The following is a description of a gene set: species: Homo sapiens Any process that modulates the frequency, rate or extent of addition of phosphate groups into a molecule. Human Gene Set: GOBP_REGULATION_OF_PHOSPHORYLATION, and this is the list of marker genes: FBLN1, CCNG1, RACK1, CARD10, SRPX2, PPIA, EGF, LATS1, C3, TRAF3IP1, BMP2, MAP4K2, CLIP3, TRAF6, KCTD20, PRKN, MAP2K1, TRAF4, DSTYK, SOCS5, SMG8, HDAC3, RBL1, DIRAS2, ROPN1, SIRT1, KLHL31, RALBP1, APOE, IL18, CDK12, AGT, TARBP2, WNT5A, CDK5RAP1, DNAJA1, CDC6, LYN, SEMA4D (semaphorin 4D), EMP2, CASS4, DOK7 (NCBI Gene Id 619409), NOP53, GPRC5A, SMO, GTF2H1, NPPA, HERC5, ADAR, HLA-DRB1, WEE2, TCIM, CDKN2A, CDK2AP1, MACROH2A1, DDRGK1, PDCD4, DIRAS3, DEFB114, CNOT9, STK4, MMP9, MAD2L2, INCA1, ZC3H12A, TRIM27, IFNG, KIT, PTEN, IGF1, CDC25C, STRADB, LIMCH1, TNK2, PAK2, MST1, CACTIN, DIPK2A, CHP1, DRD4, AGAP2, PIH1D1, CD4, GPRC5B, PTPN13, HIPK3, ENG, TPD52L1, UNC119 (NCBI Gene Id 9094), FGF1, EEF1A2, LDB2, PTK2, CLSPN, RAP1A, FLT4, ALS2, ARRB1, XRCC6, ITGB2, ARL2BP, TIGAR, KDR, ZNF622, CDK5R2, NT5DC2 (5'-nucleotidase domain containing 2), PTK2B, ZBED3, PTPRC, MEN1 (menin 1), MOB1B, KSR1, PSMD10, ENPP2, PRR5L, THBS1 (thrombospondin 1), PFN2, NDUFS4, FZD7, GPER1, FGF19, RAP2C (RAP2C, member of RAS oncogene family), FGF16, CDKN1B, RAF1, PDCD10 (NCBI Gene Id 9226), ATG14, VPS25, IL34, TLR6, BCCIP, EZH2, TNFSF15, ARHGEF5, MAP3K10, MAP3K4, ETAA1, DYNAP, WNK3, DIRAS1, VEGFA (NCBI Gene Id 7422), IL21, TBX1, EPHA7, BRAT1, MAP2K2, INHBA, FLOT1, CDK5RAP3, RAP2B, OSM, FAXDC2, GCKR, DSCAM, ADARB1 (NCBI Gene Id 104), ROPN1L, ZGPAT, ITGB1BP1, FGFR3, PKIA, PIK3R5, TAOK3, RARRES2, CD74, FIRRM, NPRL2, TSG101, JTB, THBS4, ANG, ERRFI1, SPHK1, CREBL2, TENM1, ADAM17, TOM1L1, PRKCH, SERTAD1, DNAJC3, SYNPO2, CIB1, IFNL1, SRC, CNKSR3, PHIP, NEK10, YWHAG, ABL1, CIMAP3, RAPGEF2, CADM4, RGS14, HES1, TNFRSF10B, CDC37, TNFSF18, CDC25A, FGF2, CEP85, FGFR1, BRAF, ERN1, STK11, LMO4, HRG, ERCC6, HSPB1, SIRT2, PARP9, IL20, PLXNB2, ROPN1B, FN1, PARP14, C9orf72, TAF7, ARHGEF2, LACRT, PTK6, NSD1, GRB10, CACUL1, ADCY8, FKBP8, IL15, MVP, LDB1, RAP2A, MST1R, CDKN1C, LIF, TAB2, SRCIN1, IRGM, SLIT2, S1PR2, LCP2, CORO1C, DEPTOR, CCNY, ABI1, ANGPT4, IL12A, PTPN1, NLRP2B (NCBI Gene Id 286430), CCNT2, TRIB2, NRP1, DHX34, PDGFB (NCBI Gene Id 5155), PILRB, CHMP6, PIN1, EREG, DYNLL1, S100A12, TFAP4, SNX6, CEMIP, SAMSN1, SASH1, FGF10, SNX9, CARD14, MIDN, DUSP1, CCNT1, NEDD9, TRIM6, FLT1, PRKDC, XRCC5, ODAM, THPO, JAK2, ZFP91, HNRNPU, SNF8, NPM1, ERBB2, LILRA5, FLT3, TNIK, SPRY2, KDM4D, IKBKB, TLR3, GLMN, TGFB1, NIBAN1, WDFY2 (WD repeat and FYVE domain containing 2), BCL10 (BCL10 immune signaling adaptor), CAB39, GAS6, IL11, MAP3K5, ANGPT1, AIDA, CDKN3, ACP4, PLAUR, RBL2, CNTF, NRG1, PRLR, GADD45A, PAQR3, CALCA, RSPO1, TRAF2, BLM, CD300A, CCDC88A, RB1, CTF1, TRIB1 (tribbles pseudokinase 1), TNF, CNOT7, MAP3K7, VEGFB, SESN2, CCNK, RALB, CSPG4, BARD1, RASSF2, ACVR2A, SDCBP, CCNE2, LTF, RIPK1, STRADA, STK38, FGF18, PIBF1, PTPN2, MUSK, UVRAG, AKT1, ERBB4, SERPINB3, ECT2, SPDYA, RAD17, MAPK8IP1, EFNA1, CAMK1, AKTIP, ADIPOQ, AREG, PYCARD, GSKIP (NCBI Gene Id 51527), MYDGF, ELANE, MIF, ANKLE2, RIPK3, CENPE, SOCS4, KIF14, DBNDD2, CHI3L1, COPS8, CDKN1A, TRIB3, CEP43, LAT, UBE2K, EFNA5, HGS, MRNIP, LEP, PELI2, TNFRSF10A, ZNF16, PRDX3, SFN, FBH1, ARAF, PDGFRB, CCNYL1, MAPK1 (NCBI Gene Id 5594), STOX1, PARD3, ZFYVE28, RTRAF, CD80, FER, CEACAM1, PIM1, ITLN1, PKMYT1, XBP1, AKT1S1, ROCK2, TPX2, DMTN, FBN1, NPTN, TNFRSF18, TERF2IP, IGFBP3 (insulin like growth factor binding protein 3), PSEN1, PROM2, RAC1, PDGFA (NCBI Gene Id 5154), FAM20A, MMD, DUSP7, MT3, TARDBP, PTPN22, THY1, NLRC5, SFRP1, CAMKK2, RASIP1, PTPRJ, PIK3CG (phosphatidylinositol-4,5-bisphosphate 3-kinase catalytic subunit gamma), FGR, RHOA, ZNF268, BANK1, PPP1R15B, BMP4, RIPK2, INPP5F, FGF7, HMGA2, APLN, PDCL3, PPM1E, IBTK, ADCYAP1, INSM1, MAP3K11, STAT2, HEG1, APC, IL6, NHERF1, CDK5R1, MAP2K3, PRKCD, DDR2, PIK3R6 (NCBI Gene Id 146850), MYCNOS, WARS1, LATS2, CRIPTO, CSF1R, INHA, KNDC1, RASGRP1, EGFR, MMD2, IL31RA, SFRP2, TSPYL2, MCM7, SYAP1